The following is a description of a gene set: The chemical reactions and pathways resulting in the formation of a nucleoside phosphate. species: Homo sapiens Human Gene Set: GOBP_NUCLEOSIDE_PHOSPHATE_BIOSYNTHETIC_PROCESS, and this is the list of marker genes: LIPA (lipase A, lysosomal acid type), NDUFB1, ELOVL5, ATP5MJ, VPS9D1, HACD1, CDA, NDUFB10, HPRT1, ACSBG2, NUDT2, PMM2, NDUFB8, SNCA, AK7, ADCY6, NANP, ENTPD8, UGDH, TK1, ATP6V0C, NDUFA5, IL4, PGM3, NME1, DCTD, GUCA1A, PDK1, TMSB4X, PRKAG2, GARS1, ATP5MC2, NDUFS4, PANK3, NPPC, ACOT7, GMPPA, ATPSCKMT, MTHFD2L, NDUFA13, LDHC, RRM2, ACAT1, NME3, RD3, CMAS, UPRT, FASN, GCDH, ADCY5, MAP2K1, ACSL1, ELOVL1, IMPDH1, ACSL6, PDHA1, UCK2, GUCY1B1, AMPD3, PDHB, NME4, PPARA, ADCY10, ADCY9, IDH2, GUCY2C (NCBI Gene Id 2984), UMPS, FPGT, NDUFS5, GUK1, RFK, FAM3A, UPP2, COASY, ACACB, MPI, APRT, HACD2 (3-hydroxyacyl-CoA dehydratase 2), ACACA, IDO2, RRM1, GUCA1ANB-GUCA1A, ATP5F1D, MT-ND4L, SDHD, FCSK, NDUFB2, GMDS, NDUFA9, NPPA, NME6, NDUFB7, HSD17B12, CBR4, IMPDH2, AK3, NANS, NDUFA1, GART, SPHK2, CTPS1, NDUFV1, DNAJC30, GUCY1A1, NME2, AK9, ANTKMT, PANK1, ASPDH, ELOVL4, ATP5MGL, AK5, DUT (NCBI Gene Id 1854), ATP5PD, GUCY2D, NAPRT, DCK, NDUFS7, NDUFA12, NPR1, PPT1, PRPS1, ACSBG1, SDHC, SLC25A13, PAPSS2, NDUFAB1, GMPS, NDUFA6, DLAT, STAT3, NPR2, GFUS, NDUFA7, LETMD1 (LETM1 domain containing 1), ACSS1, CAD, NDUFA3, SLC52A3, NDUFV2, SLC35A1 (NCBI Gene Id 10559), ATP5MK, UGP2, NDUFB6, AK1, DIP2A, FLAD1, NDUFA10, ATP5F1B, PDK4, PRPSAP1 (phosphoribosyl pyrophosphate synthetase associated protein 1), ELOVL3, ATP5F1EP2, PRPSAP2, PDK2, MLYCD, AMPD2, AK2, UAP1, PDK3, DCAKD, ATP5F1A, GNE, NAGK, NDUFA2, PAICS, DTYMK, UPP1, KMO, ATP5PO, ATP5IF1, GNPDA2, NME9, MMUT, HAAO, NMNAT2, MT-ND4, NDUFB4, NDUFC2, PPCDC, ACSL4, IDO1, DMAC2L, AK6, AFMID, SLC27A2, TBPL1, NDUFB9, KARS1, PRPS2, PRPS1L1, ATP5MG, FUOM, NDUFV3, STOML2, ATIC, PARP1, PFAS, SLC35C1, AMDHD2, NDUFA11, NDUFS1, ELOVL2, AK4 (adenylate kinase 4), ACSF3, ATP5PF, MPC2, ME1, ADCY1, UCKL1, DHODH, UCK1, NDUFB3, NME5, MT-ND2, MTHFD1, PINK1, GMPPB, PPAT, MIR675, ADSL, ACSS2, ATP5PB, NDUFB5, NPPB, MT-ND3, GFPT1, ADSS1, MT-ATP6, ACMSD, TK2, GFPT2, ELOVL6, PAPSS1, NMRK1, ATP5MC1, VCP, NADK, ENO1, TAFAZZIN, UAP1L1, MT-ND1, SLC4A7, PDHA2, PPCS, ALDOA, ADCY2, TGFB1, ACSL5 (NCBI Gene Id 51703), MT-ND5, TECR, GUCY2F, PPT2, ACSL3, NADK2, DGUOK, HK1, TREM2, ATP5F1E, ELOVL7, ADCY8, NMRK2, CTPS2, NDUFS2, ADCY4, ATP5MC3, ADK, AK8, RRM2B, GNPDA1, HTD2, NDUFC1, DLD, ACLY, UQCC3, CMPK1, PGK1, ADCY3, NMNAT3 (NCBI Gene Id 349565), TPK1, SDHA, NMNAT1, ADA, GNPNAT1, PMM1, NDUFS6, MT-ND6, MT-ATP8, NAMPT, GUCY1A2, NDUFS3, SDHB (NCBI Gene Id 96200, succinate dehydrogenase complex iron sulfur subunit B), AMPD1 (NCBI Gene Id 270), ADSS2, ADCY7, KYNU, NME2P1 (NME2 pseudogene 1), NADSYN1, CMPK2, PRKN, PANK4, ATP5MF, TYMS, PDHX, PANK2, ATP5F1C, NDUFB11, ATP5ME, NDUFA8, BCKDK, NME7, NDUFS8, SHMT1, PID1, QPRT, PNP, UXS1, COX11